The following is a description of a gene set: studied in species Mus musculus Genes predicted to be targets of miRBase v22 microRNA mmu_miR_344b_3p in miRDB v6.0 with MirTarget v4 prediction scores > 80 (high confidence targets). from publication Chen Y, Wang X (PMID 31504780) Mouse Gene Set: MIR_344B_3P, and this is the list of marker genes: 4933428G20Rik, Bnip2, Vegfa, Kbtbd4, Uri1, Wbp4, Dse, Mesd, Krtap9-20, Treml1, Slc20a1, Dnajc9, Scamp1, Tmem220, Pip4k2c, Mpp4, Mxd3, Nol8, Zgrf1, Pgr15l, Mogs, Rgs2, Smad1, Septin10 (NCBI Gene Id 103080), Grhl2, Nfyb, D17H6S53E, Anln, Jmjd1c, Gabra6, Gvin1, Txndc5, Klf12, Lrrtm2, Tmod2, Ap5z1, Gm8369, Bbs10, Cfap20, Ehd4, Gins3, Cpne4, Oaz1, Osbpl1a, Fgf14 (fibroblast growth factor 14), Slc25a3, Ibsp, Rfx3, Gpa33, Gvin2, Ccdc14, Actl6a, Pwwp3b, Fancl, Ms4a4c, Slk, Pcdh11x, Krtap24-1, Satb1, Specc1, Mtmr10, St18, Shoc2, Krt6b, Mybl1, Ubl3, Usp15, Upk3a, Irx3, Tspo, Ube2w, Yipf3, Spag11a, Wrn, Nufip2, Nkx2-2, Lrp11, Lca5, Abcc5, Gm3985 (predicted gene 3985), Gpr101, Smc3, Asb3, Unc13c, Cdh20